The following is a description of a gene set: studied in species Mus musculus Mouse Gene Set: GOBP_REGULATION_OF_PROTEIN_MATURATION Any process that modulates the frequency, rate or extent of protein maturation., and this is the list of marker genes: Rps6ka2, Angptl8, Nkd2, Tnp2, Snx12, Tnp1, Rfx4, Mmp14, Timm17a, Cpb2 (NCBI Gene Id 93820), Rasal2, Ctsz, Anxa2, Cwh43, Bag2, Il1r2, Nlrc4, Lrrk2, Rnf139, Plat, Timm23, S100a10, Prss37, Serpinf2, Cln3, Mdm2 (NCBI Gene Id 69330), Prkacb, Cntn2, Glg1, Plau, Serpine2, Cdh1, Plaur, Eno1, Thbs1, Ppp1r15a, Cdk20, Notch4, F12, Sirt4, Mbl2, Ift52, Sox4, Furin, Astl, Ift88, Serpine1, Rhbdd1, Acp4, Hpn, Gas1, Tfr2, Chac1, Prkaca, Ctnnd1, Plgrkt, Gsn (NCBI Gene Id 227753), Inpp5b (inositol polyphosphate-5-phosphatase B), Ldlrad3, Fuz, Meltf, Usp17le, Spon1, Ccbe1, Ctla2a, Tmem98, Eno1b, Fmr1, Src, Myh9, Clec3b